Given this list of marker genes RNF128, DHX35, COMMD3, DCX, DUSP16, P3H4, TENT5C, TPM1, FGF4, RHOT1, DNALI1, SOX5, CD40LG, KCNG4, CYP21A2, TNS2, TNXB, MYBPC2, NFIL3, HAS3, CYCS, CORO6, SF3B5, TOMM40, CCDC9B, DMRT2, YTHDF3, PLA2G4B, CDK18, HSD11B1L, USP3, TSHZ2, TBX5, PRKAG1, AGBL2, YPEL4, OPA3, RBM24, TRIM55, STOML2, LDLRAP1, GRM2, RALGAPB, CDK16, TGM5, DEFB119, LBHD1, THRA, RELT, RAB22A (RAB22A, member RAS oncogene family), RGL2, EIF1AD, CDK2AP2 (cyclin dependent kinase 2 associated protein 2), BAZ2A, FGF17, ZNF143, GNAT1, DLX1, MLLT6, ESRP2, NPAS2 (neuronal PAS domain protein 2), EIF4E, TRIAP1, BNC2, CARMIL3, HHATL, IL27, TRMT2A, BTK, HIPK2, POGK, UQCR10, NFE2L1, FOXA1, SPATA7, YARS1, AP4M1, CHD6, SHISA6, MICOS13, AIM2, CRISPLD2, MNT, SCT, WWC1, MANF, TMEM119, DCHS2, DDIT4L, CITED2, NKX6-1, CYC1, IGFBP3, ANKMY2, SHH, BPIFA2, ONECUT1, KCNAB3, JPH2, HAPLN2, IGSF9B, CDKL5, MCAM, SARM1, GAL3ST3, ELAVL2, NXPH4, ELOVL6, RGS7, TNFRSF12A, NTF4 (NCBI Gene Id 4909), LRP5 (NCBI Gene Id 8058), C1QTNF4, SND1, FGF11, ARHGAP36, JUNB, DAO, COX5A, MXI1, TBX3, PCBP4 (poly(rC) binding protein 4), CTNND2, TCF7, RELL2, BANF1, CREM, MAEA, KRT10, GUCA1A, ACSL5, SMARCA1, VAX1, SSPN, SLITRK1, GOLGA7, FXYD5, EPHA7, CITED1, MYLK2, NOG, ALPI, MTMR3 (myotubularin related protein 3), APBB1, CXXC4, XYLT2, GSE1, PAX1, PTMS, SYNGR1, MCM7, LHX5, CUL7, ENSG00000291228, RNF112, GPR162, STIM1, ZMYND8, ACKR3, KCNN3, PAX6, ZNF362, BEST4, CXCL17, MAX, FBXL22, ME3, IGDCC4, GP1BB, LDHB, PRSS27, CNBD1, PDHB, NT5C3A, LUC7L3, MAP3K13, KDM2B, CACNA2D2 (NCBI Gene Id 9254), NYAP1, DRP2 (dystrophin related protein 2), MIR9-1HG, CDHR5, LRRN1, BEND4, RAB30, FKBP10, DSPP, BCL9, OGT, KCNN2, AHNAK, SIAH3, WNT2, TMEM74B, BARHL1, SCUBE3, CCL20, LRRTM4, CUTA, DRD3, RANBP1, PAX3, RARG, ZDHHC7, MT2A, TNKS1BP1, ATP1A2, SNCB, CACNA2D3, LRR1 (NCBI Gene Id 122769), BZW2, FOXC1, THPO, MYOM3, ONECUT2, TMEM135 (NCBI Gene Id 65084), ALPG, SALL1, FGF12, BCL6, TPPP3, ATF6, RERE, TMEM8B (NCBI Gene Id 92973), NR6A1, HNRNPL, PIPOX, LMO4, TMEM215, AGO1, SYNPO, HOXC8, AIFM1, SIPA1, NFIX, STAG2, KDM6A, RPS6KA5, RAP1GAP2, PDK2, NNAT, SLC8A3, MTMR4, ABR, OBSCN, TOB1, PIK3C2G, KCNH2, JAKMIP1, NAA25, SMOC1, VAMP2, SEMA6C, BRAF (B-Raf proto-oncogene, serine/threonine kinase), CCDC140, ENPP5, here is a description of the gene set: species: Homo sapiens Human Gene Set: T3R_Q6 Genes having at least one occurrence of the motif MNTGWCCTN in the regions spanning 4 kb centered on their transcription starting sites. This matches the transcription factor binding site V$T3R_Q6 (v7.4 TRANSFAC).